The following is a description of a gene set: Ebstein anomaly of the tricuspid valve Human Gene Set: HP_EBSTEIN_ANOMALY_OF_THE_TRICUSPID_VALVE studied in species Homo sapiens Ebstein's anomaly refers to an abnormally placed and deformed tricuspid valve characterized by apical displacement of the septal and posterior tricuspid valve leaflets, leading to atrialization of the right ventricle with a variable degree of malformation and displacement of the anterior leaflet., and this is the list of marker genes: YY1, NONO, TPM1, JPH2, MYH7, FREM1